The following is a description of a gene set: Proteasome comes in several varieties. From the most ubiquitous 26S proteasome, through P28 proteasomes, to the tissue-specific proteasomes such as immunoproteasome, thymoproteasome, and spermatoproteasome.<br><br>26S proteasome, responsible for most aspects of ubiquitin-dependent regulatory and quality-control protein degradation in cells, is a 2.6-MDa protein complex that consists of a barrel-shaped proteolytic 20S core particle (20S CP) of 28 subunits capped on one or both ends by a 19S regulatory particle (19S RP) comprised of at least 19 subunits. The 19S RP, which consists of a base and a lid, coordinates substrate recognition, removal of substrate polyubiquitin chains, and substrate unfolding and translocation into the 20S CP for degradation.<br><br>The 20S CP consists of four axially stacked heteroheptameric rings - two inner and two outer rings. Inner rings contain seven distinct beta-subunits (beta-1-7, officially PSMB1-7 in humans, where beta-1 corresponds to PSMB6, beta-2 to PSMB7, beta-3 to PSMB3, beta-4 to PSMB2, beta-5 to PSMB5, beta-6 to PSMB1, and beta-7 to PSMB4), while the outer rings contain seven distinct alpha-subunits (alpha1-7, officially PSMA1-7 in humans, where alpha-1 corresponds to PSMA6, alpha-2 to PSMA2, alpha-3 to PSMA4, alpha-4 to PSMA7, alpha-5 to PSMA5, alpha-6 to PSMA1, and alpha-7 to PSMA3).<br><br>P28 proteasomes consist of the 20S CP and a P28 regulatory particle that does not have a ubiquitin receptor and comes in at least two different types of heptamers: P28-alpha-beta, composed of PSME1 (P28alpha) and PSME2 (P28beta), and P28-gamma, composed of PSME3 (P28gamma). P28 proteasomes are thought to be important for rapid degradation of misfolded proteins under conditions of oxidative stress.<br><br>In the immunoproteasome, the 20S CP inner ring subunits with proteolytic activity, PSMB6 (beta-1), PSMB7 (beta-2), and PSMB5 (beta-5), are substituted with PSMB9 (beta-1i), PSMB10 (beta-2i), and PSMB8 (beta-5i), respectively, and this variation of the core particle is known as 20S iCP. The immunoproteasome generates substrate cleavage patterns that enhance loading of peptides onto the class I major histocompatibility complex (MHC I) for immune presentation to killer T cells. Immunoproteasomes utilize the P28 regulatory particle.<br><br>In the thymoproteasome, expressed in the thymus, the 20S CP inner ring proteolytic subunits PSMB6 (beta-1), PSBM7 (beta-2), and PSMB5 (beta-5), are replaced with PSMB9 (beta-1i), PSMB10 (beta-2i) and PSMB11 (beta-5t), respectively, and this variation of the core particle is known as 20S tCP. Thymoproteasomes appear to increase the repertoire of self peptides for positive selection during T cell development in the thymus. The regulatory particle used by thymoproteasomes is not known.<br><br>In the spermatoproteasome, specifically expressed in differentiating spermatocytes, the outer ring subunit PSMA7 (alpha-4) is replaced with PSMA8 (alpha-4s). Spermatoproteasomes use the 19S RP and include an additional component, PSME4 (PA200).<br><br>An important endogenous inhibitor of the catalytic activity of 20S CP is the protein PSMF1 (PI31).<br><br>For a high-throughput study of subunit-subunit interactions in the human 26S proteasome, please refer to Chen et al. 2008, and for the cryogenic electron microscope (cryo-EM) studies of the human 26S proteasome please refer to Lu et al. 2017 and Adolf et al. 2024. Reactome Pathway: Proteasome assembly part of: Post-translational protein modification species: Homo sapiens, and this is the list of marker genes: PSMD11, PSME3, PSMG1, PSMD12, PSMD4, PSMC1, PSMF1, PSMA6, PSMD2, PSMA2, PSMD7, PSMG2, PSMA1, ADRM1, PSMA5, PSMB4, PSMB2, PSMC3 (proteasome 26S subunit, ATPase 3), PSMB7, PSME4 (NCBI Gene Id 23198), PSMB1, PAAF1, PSMD5, PSMB10, PSMB6, PSMD8, PSMD9, PSMD13, PSMD1, PSMC5, PSMB5, PSMC4, PSMB8, PSMC6, PSMC2, PSMA4, PSMA7, PSMB3, PSMD3, PSMD14, PSME1, SEM1, POMP, PSMA3, PSMG3, PSME2, PSMA8, PSMB9, PSMB11, PSMG4, PSMD6, PSMD10